The following is a description of a gene set: Human Gene Set: GSE360_L_DONOVANI_VS_T_GONDII_DC_DN from publication Chaussabel D, Semnani RT, McDowell MA, Sacks D, Sher A, Nutman TB (PMID 12663451) studied in species Homo sapiens Genes down-regulated in comparison of dendritic cells (DC) exposed to L. donovani versus DCs exposed to T. gondii. Monocyte-derived dendritic cells (DC) and macrophages (MΦ) generated in vitro from the same individual blood donors were exposed to five different pathogens, and gene expression profiles were assessed by microarray analysis. Responses to Mycobacterium tuberculosis and to phylogenetically distinct protozoan (Leishmania major, L. donovani, Toxoplasma gondii) and helminth (Brugia malayi) parasites were examined, each of which produces chronic infections in humans yet vary considerably in the nature of the immune responses they trigger., and this is the list of marker genes: ID2, HMGB2, ITPKB, STS, ATP2B3, CADPS, GBE1, FADS1, BUB1B, DYNLT1, TRAF4, PDZK1IP1, RPA1, PRPF40A, LAMP3, MTMR4, PCNA, DPT, FDPS, NELFA, CACNG3, TMX4, GNE, PROM1, ST7, SERPINC1, TMEM131L, IGSF3, H2BC6, RUVBL1, UBE2A, CALM3, CDK5R2, AMHR2, IGF1R, NHP2, SARDH, CHRNA5, TGFA, PPRC1, N4BP2L2-IT2, GJC1, CYP24A1, MLF2, GSTP1, GABPB1, EIF2B5, ANXA6, STAR, FSHR, CHST2, MEGF6, ID1, EZH1 (enhancer of zeste 1 polycomb repressive complex 2 subunit), ANK2, PLA2G1B, MX2, NUP160, MAP1A, U2AF1, ARHGAP26, C10orf95-AS1, BEAN1, MAGEB3, SIX1, MMP3, RALGAPB, CCNE1, GCFC2, MX1, TSPAN9, GPR161, CDK1, HABP2, ALDOC, TNFRSF9, TBL3, MYL4, EIF1AX, NAP1L4, KCNJ5, IGF2BP3, GABRA5, FBL, TRIM33, GART, FOXC1, CHD4 (NCBI Gene Id 1108), ADAM7, NUP188, HSPB3, H2BC12, CNN3, TULP2, MCM5, MMP16, LAGE3, NOTCH3, CTNNA1, WIPI2, SCCPDH, DNAJB12, MTOR, RPL15, SLC5A6, HDAC6, IGFBP4, PGRMC2, IQCE, CRYGA, EPHX1, DHCR7, CMC4, GFAP, KIAA0232, OFD1, IGLV1-44, EVPL, SRSF7, SOX15, SV2C, IFI44, MAST2, SQLE, ITSN1, MTR, MCM6, AURKA, IGFALS, C1orf21, CBR3, HBBP1, XRCC1, OASL, GORASP2, RNF115, ACOT8, KIF1A, IGFBP2, NDUFS6, KAT6B, VNN1, KBTBD11, IVL, CXCR1, SLC7A1, PRMT1, NME1, AP3B2, ACTN4, BCL11A, RPE65, MAD2L1, BIRC3, FOXM1, SMARCA1, FOXO1, MSH2 (mutS homolog 2), NPAS3, TRIM26, ILF3, SLC35D1, RABGAP1L, ZC3H7B, ALDH3B2, BICDL1, IGLV3-25, MIA, FST, TNFSF4, NME4, CENPS, CCL8, STMN1, CTIF, CTDSPL, NFKB1, NEU3, PGM1, NMI, NOP56, POLA2, COX4I1, C6orf47, MARCKSL1, LMTK2, ARK2N, VPS13A, CNP, HMGCS1, RGN, ICAM4, LINC00302, H2AZ1, LPAR1, RAN, PIP5K1B, KCNJ9